Given this list of marker genes Eefsec, Txnrd1, Cth, Sp3, Pstk, Trnau1ap, Jun, Selenbp1, Sephs2, Rpl30, Selenom, Dio1, Nfkb1, Msrb1, Secisbp2 (NCBI Gene Id 75420), Fos, Sars2 (NCBI Gene Id 71984), Selenow, Selenon, Gpx6, Selenbp2, Selenoi, Txnrd2 (thioredoxin reductase 2), Gpx1, Selenoo, Dio3, Txnrd3, Gpx4, Rela, Crem, Fabp1, Sephs1, Dio2, Scly, Sp1, Nfe2l2, Gpx2, Pou2f1, Selenok, Sars1, Selenov, Selenot, Sepsecs, Selenop, Selenos, Gpx3 (NCBI Gene Id 14778), Selenoh, here is a description of the gene set: Selenium metabolism / selenoproteins species: Mus musculus Mouse Gene Set: WP_SELENIUM_METABOLISM_SELENOPROTEINS